The following is a description of a gene set: Tumor growth is associated with a profound alteration of myelopoiesis, leading to recruitment of immunosuppressive cells known as myeloid-derived suppressor cells (MDSCs). Analyzing the cytokines affecting myelo-monocytic differentiation produced by various experimental tumors, we found that GM-CSF, G-CSF, and IL-6 allowed a rapid generation of MDSCs from precursors present in mouse and human bone marrow (BM). BM-MDSCs induced by GM-CSF+IL-6 possessed the highest tolerogenic activity, as revealed by the ability to impair the priming of IFN- -producing CD8+ T cells upon in vivo adoptive transfer. Moreover, adoptive transfer of syngeneic, GM-CSF+IL-6-conditioned MDSCs to diabetic mice transplanted with allogeneic pancreatic islets resulted in long term acceptance of the allograft and correction of the diabetic status. Cytokines inducing MDSCs acted on a common molecular pathway. Immunoregulatory activity of both tumor-induced and BM-derived MDSCs was entirely dependent on C/EBP transcription factor, a key component of the emergency myelopoiesis triggered by stress and inflammation. Adoptive transfer of tumor antigen-specific CD8+ T lymphocytes resulted in therapy of established tumors only in mice lacking C/EBP in myeloid compartment. These data unveil another link between inflammation and cancer and identify a novel molecular target to control tumor-induced immune suppression. We used gene expression analysis to identify those factors, secreted by tumor-infiltrating MDSC, which could drive emathopoiesis. Moreover we compare gene expression profile of tumor-induced MDSC, obtained from either the spleen and the tumor infiltrate of tumor bearing mice, and in vitro bone marrow-derived MDSC. Human Gene Set: GSE21927_HEALTHY_VS_TUMOROUS_BALBC_MOUSE_MONOCYTE_DN Genes down-regulated in CD11b+ cells from spleen of BALB/c mice: healthy versus bearing C26GM colon carcinoma. species: Homo sapiens from publication Marigo I, Bosio E, Solito S, Mesa C, Fernandez A, Dolcetti L, Ugel S, Sonda N, Bicciato S, Falisi E, Calabrese F, Basso G, Zanovello P, Cozzi E, Mandruzzato S, Bronte V (PMID 20605485), and this is the list of marker genes: LINC00877, DSCR4, ADGRF2P, SPIN2A, LCK, RNF157-AS1, SDHA, NNMT, MAP1LC3C, PCP4, NPY6R, MAP4K3-DT, CPS1, ZNF826P, STXBP5-AS1, TMPRSS12, EVPLL, SLC22A3, CCDC120, ADAMTS1, SULT1B1, MYO16, LINC03103, GABPB1-AS1 (GABPB1 antisense RNA 1), ZNF514, CDH6, LINC00567, PRICKLE1, RABGEF1P1, STYK1, CNTNAP2, FOLR3, PLA2G10, SLC22A9, TMEM102, CREB1, CALCR, PWP1, GARS1, DENND2C, CXCL2, ZNF554, CLDN7, TCP10L, MT1E, BRD4, SPRR3, LAMB4 (NCBI Gene Id 392775), PSG4, KBTBD12, SH2D1A, SPHKAP (SPHK1 interactor, AKAP domain containing), MAP1B, DICER1, MRGPRX1, GALNT17, SLC17A8 (solute carrier family 17 member 8, NCBI Gene Id 64944), OTP, SYVN1, TFAP2E, KCNB1, BLTP3A, LINC01550, KLHL6, PDCD1LG2, TADA2A, NFE4, LERFS, NEUROG3, LINC00943, TMEM182, WBP2NL, AIFM1, TTI2, CES3, ZNF562, PUS3, BLTP2, ZC2HC1A, CMIP, PIGZ, DNAJC16, PROX1-AS1, LINC01996, PRSS58, REG4, CALHM1, VAMP8, CPXCR1, PGM5-AS1, OSBPL10, AMZ2, LINC00906, GRK1, BEND3, SLC22A2, HHLA2, INTS6, TMEM158, ZMIZ1-AS1, TENM4, TNFSF4, ZNF428, PACSIN2, TREML4, CRYM, CASKIN1, UNC13C, RIPPLY3, DAPK2, ZNF582 (NCBI Gene Id 147948), DDX10, SPATA32, NOX1, SPATA4, PRM2, APOBEC3A, PGF, ZKSCAN5, NT5C1A, HSPA14, CSMD1, FAM106A, METTL15, LINC00968, FGL2, CRHR2, HAND2-AS1, SLC30A2, ARHGAP22, ZNF519, LINC00421, SPINK6, KCNK16, PPP1R10, ACP2, FOXC2, PSME1, LINC00612, ACMSD, ENSG00000290598, TAF13, MX1, HAR1A, HIPK3 (homeodomain interacting protein kinase 3), FBXL21P, GPATCH2, NAXD, BCL9L, LRRIQ1, IGFBP5, PCDHGA8, LCE1E, NOS2, EIF4A1, METTL23, PHRF1, HLA-DPB2, GSC (goosecoid homeobox), OR4C1P, LUZP4, SERINC3, PAPLN, HAS3, LINC01341, ZBTB20, TRBC1, ZBTB16, C7orf57, IGFL2, ADGRF1, CRYBG1, POMGNT1, SFTPD, ZNF271P, FAM111B, SCGN, RAD1 (NCBI Gene Id 5810), ZNF547, UACA, RBM11, OR1E1, RIC3, LRRC23, DPEP2, ARHGEF38, DACH2, GRK7